Given this list of marker genes Sh3glb1, Irs2, Irs3, Irs1, Lyn, Prkd1, here is a description of the gene set: Binds to and increases the activity of a phosphatidylinositol 3-kinase (PI3K). studied in species Mus musculus Mouse Gene Set: GOMF_PHOSPHATIDYLINOSITOL_3_KINASE_ACTIVATOR_ACTIVITY